The following is a description of a gene set: from publication Ivanova NB, Dimos JT, Schaniel C, Hackney JA, Moore KA, Lemischka IR (PMID 12228721) Human Gene Set: IVANOVA_HEMATOPOIESIS_STEM_CELL Mechanisms regulating self-renewal and cell fate decisions in mammalian stem cells are poorly understood. We determined global gene expression profiles for mouse and human hematopoietic stem cells and other stages of the hematopoietic hierarchy. Murine and human hematopoietic stem cells share a number of expressed gene products, which define key conserved regulatory pathways in this developmental system. Moreover, in the mouse, a portion of the genetic program of hematopoietic stem cells is shared with embryonic and neural stem cells. This overlapping set of gene products represents a molecular signature of stem cells. Genes in the expression cluster 'HSC Shared': up-regulated in hematopoietic stem cells (HSC) from adult bone marrow and fetal liver. species: Mus musculus, and this is the list of marker genes: MYO10, SLIT2, NSD3, BAALC, LRRC49, LPAR4, ROBO4, PEAK1, ITIH5, ITGA9, WWC2, ARL4C, DNMT3A, CPXM1, S100A5, TCF25, ZBTB37, PKD2, VLDLR, GATAD2A, SLC41A1 (solute carrier family 41 member 1), SREK1, ZRSR2, ETV1 (NCBI Gene Id 221810), SKIL, NR4A2, NTRK3, SULT4A1, RFPL4B, LYPD1, VPS37A, HOOK1, PDE4B, HNRNPR, PTPRK, CCAR1, FOXB2, ZBTB20, SMARCA2, KCNK15, IFT81, BCL2L11, PGLYRP2, USP38, CYP2D6, CCDC185, ZMYND8, USP34, MARCHF9 (NCBI Gene Id 92979), TRIM61, HOXB2, PDF, SERPINB8, TBXA2R, MEX3A, CCL19, ZDBF2, SASH1, FAM168B, SYN2, RPS6KA3, RBX1, TCF4, MAFF, CDIP1, INPPL1, REST (NCBI Gene Id 5978), DUSP5, SEPTIN3, MIRLET7D, IQGAP2, AGXT, CHRNB1, SLC35F1, CAMTA1, ENG, CTNNAL1, KIF5A, PTGR1, PRKG1, ZC2HC1A, IFIH1, FBXW12, ABCC12 (NCBI Gene Id 94160), PYGM, ETV3, PPP1R9A, GATA3, IFI44, IGDCC4, SLC23A2, NRXN3, JADE1, ARHGAP32, GNL1, THA1P, SV2A, ZXDB, SOCS5, RILPL1, SAMD10, TRIM9, FUNDC2, PARD6G, LRRTM4, CHN1, TSPAN13, NR4A1, PALMD, LAPTM4B, FAM110B, POLR2A, FRMD8, SEMA3D, GEM (NCBI Gene Id 2669), SEC14L3, SEMA4C, CHRNA6, PCK1, SLC25A30, DDIT4, RASD1 (NCBI Gene Id 63428), MISFA, IL36A, TGOLN2, SGSM1, GAPDHS, TCTN2, NFKBIA, DNAJC21, HYAL1, SYT11, EMP1, WNT6 (NCBI Gene Id 7475), DYDC1, COL4A1, CCDC136, MYCBP2, PLAC8L1, PRCD, NFIX, SCAF11, DNAJB13, GLB1L, NFATC2, ASH1L, VAMP2, MEF2D, NRXN1, ZCCHC7, EFNA3, ITGA3, SMAD7, RBBP6, EMCN, CD164L2, PRKCE, ZC3H12C, NKAIN3, COL18A1, CLPS, IGLV1-50, ESR1, KCNJ6, NFKBIE, PAIP1, CERS4, JUN, CXCL14, RBM28, KLHL26, NCOA2, FAM181B, ARHGEF28, SOS1, PEX11A, SMC5, CYP2E1, COBLL1, ARHGAP42, CDK14, TSPAN6, SIAH2, EGR1, NKX2-8 (NCBI Gene Id 26257), PDC, PRKACB, DEF8, SLC16A5, MSI2, PITPNC1, CPSF2